The following is a description of a gene set: Human Gene Set: GOBP_NEURON_PROJECTION_ORGANIZATION A process that is carried out at the cellular level which results in the assembly, arrangement of constituent parts, or disassembly of a prolongation or process extending from a neuron, e.g. an axon, or a dendrite. species: Homo sapiens, and this is the list of marker genes: VPS35, ARMCX5-GPRASP2, PICK1, WNT7A, APOE, SHANK1, SIPA1L1, ABCD1, MTMR2, CAPRIN1, NMNAT3, APP (amyloid beta precursor protein), IL1RAPL1 (interleukin 1 receptor accessory protein like 1), DCTN1, ZNF365, GSK3B, DTNBP1, PDLIM5, HOMER1, FCGR2B, PTPRD, PSEN1, EPHB3, MAP1A, EPHB2, CTTN, CDK5, CAPRIN2, MIR30B, KIF1A, ITGA3, CDC42, PLS1, ARHGAP33, ADCY10, PAK3, ARHGAP44, LRRK2, TANC1, ABI3, EFNA1, ATP1A3, LRP8, ZMYND8, ABCD2, TREM2, NMNAT2, INSR, GPRASP3, LGMN (legumain), CHRNA7, SHANK3, NGEF, NMNAT1, DLG4, CFL1, HDAC6, PAFAH1B1, FYN, KIFBP, DIP2A (NCBI Gene Id 23181), EPHB1, NLGN1, ZNF804A, BAIAP2, DBN1, DVL1, PTEN, DHX36, TANC2, SLC30A1, ZDHHC15, GRIN2B, EEF2K, DOCK10, IGF1R, EPHA4, CAMK2B, SRCIN1, LZTS3, ABI2, ITPKA, RELN, STAU2, CUX2, ARF1, CDK5R1, ABHD17B, CTNND2, PPFIA2 (NCBI Gene Id 8499), PRNP, NEDD9, INS, WASL, ARC (NCBI Gene Id 53837)